The following is a description of a gene set: Genes down-regulated in biphasic (mixed) vs epithelial subtypes of malignant peritoneal mesothelioma. studied in species Homo sapiens Malignant mesothelioma is an aggressive neoplastic proliferation derived from cells lining serosal membranes. The biological and clinical characteristics of epithelial type malignant mesothelioma are distinct from those of biphasic and sarcomatous type tumors. The goal of our study was to examine the molecular basis for this distinction. Microarray analysis confirmed that the molecular signatures of epithelial and biphasic histologic subtypes were distinct. Among the differentially expressed functional gene categories was the ubiquitin-proteasome pathway, which was upregulated in biphasic tumors. Cytotoxicity experiments indicated that 211H cells derived from biphasic tumors were synergistically sensitive to sequential combination regimens containing the proteasome inhibitor bortezomib and oxaliplatin. The mechanism of this synergistic response, which was not detected in cells of epithelial tumor origin, was apoptosis. Together, our results identify the ubiquitin-proteasome pathway as a biomarker of poor prognosis biphasic peritoneal mesothelioma tumors and suggest that proteasome inhibitors could increase the effectiveness of cytotoxic chemotherapy in this subset of patients. from publication Borczuk AC, Cappellini GC, Kim HK, Hesdorffer M, Taub RN, Powell CA (PMID 16862182) Human Gene Set: BORCZUK_MALIGNANT_MESOTHELIOMA_DN, and this is the list of marker genes: TRAF1, VIPR2, RCE1, AMY1A, MEG3, NCF1, AMPD1, CD6, ATP2A1, CD22, PPT2, N4BP2L2, BORCS8-MEF2B, CD19, IL7R, DDT, FGF12, THSD7A, FSCN2, B4GALT1, LMOD1, MS4A1, RBBP6, CDKN2A, KIR2DL4, CASP10, ENSG00000235059, SEMA3B, CTTN, PRB1, OVOL3, SEMA3F, TRPC2, RAPGEF3, IGHM, CD38, PCSK7, PNOC, RDH16, ATG2A, LBX1, CAPN3, IGKV1OR1-1, CPA3, PLXNB1, LCAT, FRZB, SFPQ, IGHD, ANXA9, DENND3, CCL2, GRAP2, XPNPEP2 (X-prolyl aminopeptidase 2), CFP, HEXA, MAST4, FCMR, NCR1, ACSM1, TRAF3IP3, SF1, PTPRCAP, AOX1, RAD9A, NFIA, CPT1B, HAS2 (hyaluronan synthase 2), TAP2, CD79A, VILL, FXYD1, TCIRG1, PLA2G2A, SEZ6L, C6, CYP3A5 (cytochrome P450 family 3 subfamily A member 5), HEXIM2-AS1, CD79B, ARAP1, TPSAB1, WT1-AS, ARHGAP44, C7, STS, FKBP2, FCER2, CKMT2, ZBTB7A, ERCC5, NBEAL2, CCL21, KIR3DL2 (killer cell immunoglobulin like receptor, three Ig domains and long cytoplasmic tail 2), NKTR, CLCN1, RBMY2AP, TOP6BL, SAT1, PTOV1-AS2, MYL3, ACAP1, APOD, AGFG2, RGS16, NEAT1, CHRD